The following is a description of a gene set: The tightly packed helical sheath of ATP-producing mitochondria restricted to the midpiece of the sperm flagellum. Human Gene Set: GOCC_SPERM_MITOCHONDRIAL_SHEATH studied in species Homo sapiens, and this is the list of marker genes: AK2, PPP3R2, IRGC, HSP90AA1, SPATA33, GK2